The following is a description of a gene set: Human Gene Set: GOMF_CALCIUM_DEPENDENT_PROTEIN_SERINE_THREONINE_PHOSPHATASE_ACTIVITY species: Homo sapiens Catalysis of the reactions: protein serine phosphate + H2O = protein serine + phosphate; and protein threonine phosphate + H2O = protein threonine + phosphate. These reactions require the presence of calcium ions., and this is the list of marker genes: RCAN3, PPP3CA, PPP3R1, PPM1F, RCAN2, RCAN1, PPP3R2, CAMK2G, PPM1A (NCBI Gene Id 5494), PPP3CB, PPP3CC